The following is a description of a gene set: Combining with the Fc region of an immunoglobulin protein and transmitting the signal from one side of the membrane to the other to initiate a change in cell activity. studied in species Mus musculus Mouse Gene Set: GOMF_IMMUNOGLOBULIN_RECEPTOR_ACTIVITY, and this is the list of marker genes: Fcgr1, Fcgr3, Fcer2a, Fcer1a, Fcmr, Pigr, Fcgr4, Ms4a2, Fcgr2b, Fcer1g